The following is a description of a gene set: Recurrent tonsillitis Inflammation of the tonsils that has occurred repeatedly. The definition of recurrent may vary somewhat, but the criteria used recently as a measure of severity were five or more episodes of true tonsillitis per year, symptoms recurring for at least a year, and episodes that are disabling and that prevent normal functioning. In some cases recurrent tonsillitis may be related to immunosusceptibility. Evidence exists for a genetic predisposition for recurrent tonsillitis. Human Gene Set: HP_RECURRENT_TONSILLITIS species: Homo sapiens, and this is the list of marker genes: IGKC, CYBC1, PIK3CD, IGHG2, TBK1, C3, MYO5A, ELANE (NCBI Gene Id 6417), SCNN1A, PTEN, BLM, SCNN1G, SEC61A1, MPEG1, PIK3R1, RIPK1, SCNN1B